Given this list of marker genes Dtymk (NCBI Gene Id 98609), Guk1, Cmpk1, Nudt18, Cmpk2, here is a description of the gene set: species: Mus musculus Mouse Gene Set: GOBP_DEOXYRIBONUCLEOSIDE_DIPHOSPHATE_METABOLIC_PROCESS The chemical reactions and pathways involving a deoxyribonucleoside diphosphate, a compound consisting of a nucleobase linked to a deoxyribose sugar esterified with diphosphate on the sugar.